The following is a description of a gene set: studied in species Mus musculus Mouse Gene Set: MIR_496A_5P Genes predicted to be targets of miRBase v22 microRNA mmu_miR_496a_5p in miRDB v6.0 with MirTarget v4 prediction scores > 80 (high confidence targets). from publication Chen Y, Wang X (PMID 31504780), and this is the list of marker genes: Oca2, Arhgef15, Sord, Entpd7, Lrrn3, Sntn (NCBI Gene Id 218739), Rab2a, Nrdc, Rcor1, Man1a2, Ntf5, Tmem243, Chchd3, Dab1, Dgkk, Spry2, Nudt16l1, Slc9a4, Abcf3, Mplkip, Akirin2, Cd24a